The following is a description of a gene set: studied in species Homo sapiens Human Gene Set: GOBP_NEGATIVE_REGULATION_OF_SODIUM_ION_TRANSPORT Any process that decreases the frequency, rate or extent of the directed movement of sodium ions (Na+) into, out of or within a cell, or between cells, by means of some agent such as a transporter or pore., and this is the list of marker genes: PRKCE, MIR24-1, OSR1, WNK4, SERPINE2, AGT, COMMD1, MIR448, NHERF1, MIR192, NEDD4L, CAMK2D, PCSK9, STK39, NEDD4, WNK1, GRP (gastrin releasing peptide)